Given this list of marker genes CHGA (NCBI Gene Id 1113), TG, EIF4H, DOK1, CBR4, MRPL45, SGO2, CENPS, GPI, FBXO5, TXN2, BLMH, ORMDL2, LUZP1, CRELD2, MCM10 (NCBI Gene Id 55388), MRPS18C, CDK4, AJUBA, SCARB1, HPRT1, MRPS11, PASK, SAE1, FH, CKAP2L, FIGNL1, PSMB1, IFT70A, DNAJC2, RFC2, BMPR1A, NAA10, KNSTRN, FAR1, UBR7, AP2S1, CYSLTR2, HSD17B12, ASPM, SNRNP25, ETFB, HADH, RBBP7 (NCBI Gene Id 5931), FBLN1, FBXO44, HDAC3, RPE, HINT1, VIM, DNAJC9 (DnaJ heat shock protein family (Hsp40) member C9), RAD51AP1, DRG1, NUCB1, SERF1A, GALE, KCNK5, SKA2, PDAP1, MX2, POLE, ABCB9, SNF8 (SNF8 subunit of ESCRT-II), SLC25A20, NUP93, CSNK2B, GTF3A, MRPL18, INO80E, UCHL5, GLOD4, HPS6, BRI3BP, CNTLN, TKT, CDCA7L, ITPR1, CNIH1, FAM216A (NCBI Gene Id 29902), SMDT1, EME1, WASHC5, SLC25A6 (NCBI Gene Id 8283), SEPTIN11, IFT43, TACC3, RPS27L, AP2M1, VWA5A, CTC1, FBXW8, PSMA4, RAB19, AAAS, TPI1, GTF2H5, GINS1, CAV3, SNHG32, MRPS16, TRAPPC1, APAF1, PDLIM2, GZMK, LRWD1, TUFM, TM4SF5, UMAD1, EIF5A2 (eukaryotic translation initiation factor 5A2), STMN1, KIF23, COPS3, CDCA2, GRIA4, GNG3, PPP3CC, AARSD1, DDX1, GNG2, GALK1, COX17, PSMD1, PDK3, RYK, VDAC1, NELFCD, LAMP2, CAD, MRE11, SEC13, APIP, MTHFD1L (NCBI Gene Id 80244), IL4 (NCBI Gene Id 3565), PPP1R7, KIF2A, SNRNP35, PIDD1, ANLN, FGL2, RNASEH2B, FNDC3B, ENTPD7, ITGAL, GTF2F2, IQGAP3, CCL5, RFC5, LETM1, ERH, CLSPN (claspin), ZNF518B, SLC31A1, MYDGF, KIF3A, GRIN2A, HEMK1, NAP1L1, CENPE, PFKP, WSB2, BRCA1, UBE2V1, UFSP2, CRYBG2, NSD2, LSM2, IDH3B, NRM, ELOVL1, POGLUT3, DDT, GNPDA1, TNFSF9, DTL, NCAPH2, PSMA2, ATPAF2, TRIM37, MIS18A, SYNPO, BAK1, EI24, NUTF2, SAR1B, GMDS, ECT2, ATP5MC3, NUF2, CHSY1, DARS1, THOP1, LRRC40, TXNDC17, GSTT2, TNFRSF8, UFC1, DEPDC1B, PPFIBP1, EMC7, PACRGL (parkin coregulated like), here is a description of the gene set: Human Gene Set: GSE43863_TH1_VS_LY6C_INT_CXCR5POS_EFFECTOR_CD4_TCELL_UP Genes up-regulated in CD4 SMARTA effector T cells during acute infection of LCMV: Th1 versus Ly6c int CXCR5+. from publication Hale JS, Youngblood B, Latner DR, Mohammed AU, Ye L, Akondy RS, Wu T, Iyer SS, Ahmed R (PMID 23583644) CD4 T follicular helper (Tfh) cells provide the required signals to B cells for germinal center reactions that are necessary for longlived antibody responses. However, it remains unclear whether there are CD4+ memory T cells committed to the Tfh lineage after antigen clearance. Using adoptive transfer of antigen-specific memory CD4+ subpopulations (based on CXCR5 and Ly6c expression)in the LCMV infection model, we found that there are distinct memory CD4+ T cell populations with commitment to the Tfh and Th1 lineages. Our conclusions are based on gene expression profiles, epigenetic studies and phenotypic and functional analysis. The gene expression profiles of virus-specific CD4 T cell subets at effector and memory stages is presented here. studied in species Homo sapiens